Given this list of marker genes ACAT1, here is a description of the gene set: Reactome Pathway: Beta-ketothiolase deficiency studied in species Homo sapiens part of: Diseases of branched-chain amino acid catabolism ACAT1 is a mitochondrial enzyme that plays a role in metabolism of ketone bodies and isoleucine catabolism. As part of isoleucine catabolism in the mitochondria, ACAT1 catalyzes the thiolytic degradation of alpha-methylacetoacetyl-CoA to propionyl-CoA and acetyl-CoA. Mutations in ACAT1 that affect protein stability and enzymatic activity are associated with beta-ketothiolase deficiency, also known as alpha-methylacetoacetic aciduria, an inborn error of metabolism that is identified by the presence of isoleucine intermediate metabolites in bodily fluids. Neonatal onset is rare and most affected individuals present between 6 and 18 months with metabolic acidosis, lethargy, vomiting and sometimes coma. As with other disorders of branched-chain metabolism, there is not a direct correlation between genotype and severity of phenotypic presentation.